The following is a description of a gene set: Reactome Pathway: IRS-related events triggered by IGF1R electronically inferred by orthology from the curated human pathway part of: IGF1R signaling cascade This event has been computationally inferred from an event that has been demonstrated in another species.<p>The inference is based on the homology mapping from PANTHER. Briefly, reactions for which all involved PhysicalEntities (in input, output and catalyst) have a mapped orthologue/paralogue (for complexes at least 75% of components must have a mapping) are inferred to the other species. studied in species Mus musculus, and this is the list of marker genes: Fgf15, Irs1, Flt3l, Pdpk1 (3-phosphoinositide dependent protein kinase 1), Fgf17, Kl, Pik3cb, Fgf4, Fgf10, Fgf23, Fgf6, Fgf22, Fgf8, Fgf2, Grb2, Them4, Irs4, Klb, Igf2, Gab1, Tlr9, Fgf20, Pik3c3, Pik3r2, Fgf7, Fgf1, Fgfr1, Fgf5, Frs2, Irs2, Fgf16